The following is a description of a gene set: Human Gene Set: GOBP_ADENYLATE_CYCLASE_INHIBITING_SEROTONIN_RECEPTOR_SIGNALING_PATHWAY studied in species Homo sapiens An adenylate cyclase-inhibiting G protein-coupled receptor signaling pathway initiated by serotonin binding to its receptor, and ending with the regulation of a downstream cellular process., and this is the list of marker genes: GNAO1, HTR5A (5-hydroxytryptamine receptor 5A), ADCY6, HTR1A, HTR4, HTR1B, HTR1F, HTR1D, GNAI1, HTR1E